Given this list of marker genes CYTH3, RGS16, ATG16L1, CCND2 (NCBI Gene Id 894), COL15A1 (NCBI Gene Id 1306), MMGT1, FARP1, CAPN6, MMP11, TAF5, PGAP1, TRIB1 (tribbles pseudokinase 1), LOXL4, PPARGC1A, SIMC1, GALNT1, HAS2, VANGL2, SLC30A4, CPEB4, DPYSL3 (dihydropyrimidinase like 3), HK2, HMGA2, MVB12B, EPHA3, XRN1, NAA15, ADAMTS9, NDST3, LUC7L3, ARMC8, GALNT2, CAP1, HOMER2, LAMP2, FBXO30, ZKSCAN2, PURG, KPNA4, CPEB3, CBL (NCBI Gene Id 867), KIF1B, KIF2A, SOX11, CALD1, MNT, SNX27, NAP1L1, CREM, DICER1, CEP164, TAB2 (TGF-beta activated kinase 1 (MAP3K7) binding protein 2), LPGAT1, RNF13, SLC38A9, SEC24C, ARL5A, IKZF4, ZSWIM4, EPS15, INO80D, SENP2 (NCBI Gene Id 59343), CSNK1G1, ZBTB10, MMD, DST (dystonin), HIC2, RFLNB, CTDSPL2, EFNB3, DLC1, LEPROTL1 (leptin receptor overlapping transcript like 1), HMGCS1, CRTAP, CSMD1, CCND1, ARK2C, GRHL2, FAR2, ZNF644, MOB4, SRGAP3, MYCN, FBXL19, LRRN3, MYRIP, STARD13, ARID3B, MIER2, DNAJB9, PPARGC1B, CAPN15, SERTAD2 (NCBI Gene Id 9792), STAB2, DUSP9, HECTD2, HECW1, YPEL2, SYT1, ADAMTS3, ASAP2, NRK, KIAA0930, MED6, GAD1 (NCBI Gene Id 50977), STARD3NL, TECPR2, KLHDC3, ADIPOR2, GABPA, GHR, ACVR2A, TBKBP1, CPEB2, PNP, RAB8B, ATXN7L2, SHANK2, SREK1IP1, RHOT1, MTMR12, XKR4, SMAP1, BTG2, LAMA1, NEK7, RORC, BOLL, RBFOX2 (RNA binding fox-1 homolog 2), INPP5A, CGN, NID2, NSD3, ADCY9, MANEAL, DCUN1D4, SCYL3, TNRC6B, COL19A1, MED13L, RB1, CALU, ABHD13, KIAA0040, DUSP1 (dual specificity phosphatase 1), UBE2W, PIK3IP1, EIF4EBP1 (eukaryotic translation initiation factor 4E binding protein 1), LIMD1, TMC7, HNRNPC, RNF139, LBH, FOXN3, AKAP13, DNAJB11, CACNA1E, SNX5 (sorting nexin 5), KBTBD8, SLC9A9, SLC25A4, KAT6A, PCDH19, RAB11FIP2, CPED1, TSPAN2, NAA40, GTPBP2, GRAMD2B, ELAVL3, CHN2, ZC3H11A, IP6K2, SLC37A4, RBFOX1, SLC16A10, IL10, BCL7A, here is a description of the gene set: species: Homo sapiens Genes having at least one occurence of the motif ATACCTC in their 3' untranslated region. The motif represents putative target (that is, seed match) of human mature miRNA hsa-miR-202 (v7.1 miRBase). Human Gene Set: ATACCTC_MIR202